Given this list of marker genes SLC25A5, CDKN3, UCK2 (uridine-cytidine kinase 2), PMAIP1, ATP5PF, ADGRE3, HMGB2, MMP1, CXCL1, ACP2, IL6 (interleukin 6), IGKC, FAS, CCNG1, CASP4, GLRX (glutaredoxin, NCBI Gene Id 90885), here is a description of the gene set: Genes up-regulated by expression of HBV X protein (HBVgp3) in SK-Hep-1 cells (hepatocellular carcinoma). Human Gene Set: WU_HBX_TARGETS_1_UP from publication Wu CG, Salvay DM, Forgues M, Valerie K, Farnsworth J, Markin RS, Wang XW (PMID 11439330) Hepatitis B virus (HBV) is a major risk factor for the development of hepatocellular carcinoma (HCC). HBV encodes the potentially oncogenic HBx protein, which mainly functions as a transcriptional co-activator involving in multiple gene deregulations. However, mechanisms underlying HBx-mediated oncogenicity remain unclear. To determine the role(s) of HBx in the early genesis of HCC, we utilized the NCI Oncochip microarray that contains 2208 human cDNA clones to examine the gene expression profiles in either freshly isolated normal primary adult human hepatocytes (Hhep) or an HCC cell line (SK-Hep-1) ecotopically expressing HBx via an adenoviral system. The gene expression profiles also were determined in liver samples from HBV-infected chronic active hepatitis patients when compared with normal liver samples. The microarray results were validated through Northern blot analysis of the expression of selected genes. Using reciprocally labeling hybridizations, scatterplot analysis of gene expression ratios in human primary hepatocytes expressing HBx demonstrates that microarrays are highly reproducible. The comparison of gene expression profiles between HBx-expressing primary hepatocytes and HBV-infected liver samples shows a consistent alteration of many cellular genes including a subset of oncogenes (such as c-myc and c-myb) and tumor suppressor genes (such as APC, p53, WAF1 and WT1). Furthermore, clustering algorithm analysis showed distinctive gene expression profiles in Hhep and SK-Hep-1 cells. Our findings are consistent with the hypothesis that the deregulation of cellular genes by oncogenic HBx may be an early event that favors hepatocyte proliferation during liver carcinogenesis. species: Homo sapiens